The following is a description of a gene set: Abnormality of fundus pigmentation Human Gene Set: HP_ABNORMALITY_OF_FUNDUS_PIGMENTATION Any anomaly of the pigmentation of the fundus, the posterior part of the eye including the retina and optic nerve. species: Homo sapiens, and this is the list of marker genes: CNGA1 (NCBI Gene Id 1259), CFI, SLC25A15, EDNRB, SLC45A2, PAX3, AIPL1 (NCBI Gene Id 23746), EFEMP1, CLRN1, PAX6 (paired box 6), OCA2, IFNG, GPR143, ARL6, KIF7, FOXC1, GUCA1A, SOX10, RLBP1, RHO, CACNA1F, RBP3, LAMB2 (NCBI Gene Id 3913), TYR, TRIM44, MC1R, PRPH2, CRX, LRAT, CHM, MITF (NCBI Gene Id 7487), BLOC1S6, CFH, APC, TSC2, GUCY2D, POU3F4, GGCX, ROM1, EPG5, MUTYH, MTTP, PDE6G, RDH5, COL4A1, TSC1, CFAP418, RPGRIP1, CAPN5